Given this list of marker genes ADK, SKIC3, GNMT, AHCY, FAH, CBS, SLC25A13, MAT1A, TFAM, here is a description of the gene set: studied in species Homo sapiens Hypermethioninemia An increased concentration of methionine in the blood. Human Gene Set: HP_HYPERMETHIONINEMIA